Given this list of marker genes Dll1, Prickle1, Hey2 (hairy/enhancer-of-split related with YRPW motif 2), Hdac3 (NCBI Gene Id 15183), Sox6, Frs2, Ccnd2, Fzd7 (frizzled class receptor 7), Dkk1, Bmp2, Smad4, Egfr, here is a description of the gene set: Any process that stops, prevents or reduces the frequency, rate or extent of cardiocyte differentiation. studied in species Mus musculus Mouse Gene Set: GOBP_NEGATIVE_REGULATION_OF_CARDIOCYTE_DIFFERENTIATION